Given this list of marker genes GNGT2, GNGT1, GNG5, GNB1, ADCY5, CACNA2D2, GNG4, GNB5, GNB4, GNG8, GNAI2, GNG10 (NCBI Gene Id 2790), CACNA1D (NCBI Gene Id 776), ADRA2C, GNG3, GNG2, GNAI1, ADCY6, CACNB2, ADRA2A, CACNB3, GNB2, GNG7, GNG12, GNG13, CACNA1C, GNB3, GNG11 (NCBI Gene Id 2791), here is a description of the gene set: The catecholamines adrenaline (epinephrine) and noradrenaline (norepinephrine) inhibit insulin secretion from pancreatic beta cells. Four effects are seen in the cells:<br>1. Inhibition of exocytosis of secretory granules, the major effect.<br>2. Opening of ATP-sensitive potassium channels (KATP channels) and repolarization of the cell.<br>3. Closing of L-type voltage-dependent calcium channels and inhibition of calcium influx.<br>4. Inhibition of adenylyl cyclase activity.<br>The first event in adrenaline/noradrenaline signaling in beta cells is the binding of adrenaline or noradrenaline to alpha-2 adrenergic receptors, which are G-protein coupled receptors. Binding activates the alpha subunits in heterotrimeric Gi and Go complexes to exchange GDP for GTP, forming the active G alpha:GTP complex. Experiments using specific antibodies against the alpha subunits in mice show that Gi alpha-1, Gi alpha-2, and Go alpha-2 are responsible for adrenergic effects. The exact beta and gamma subunits of the heterotrimeric G-proteins are unknown.<br>After activation by GTP, the heterotrimeric complex dissociates into the G alpha:GTP complex and the beta:gamma complex. The G alpha:GTP complex causes the inhibition of exocytosis by an unknown mechanism that involves protein acylation. This is responsible for most of the observed inhibition of insulin secretion. Additionally, the G alpha:GTP complex activates (opens) KATP channels, allowing the cell to repolarize. The beta:gamma complex inhibits (closes) voltage-dependent calcium channels, reducing the intracellular calcium concentration, and inhibits adenylyl cyclase, reducing the intracellular cAMP concentration. Reactome Pathway: Adrenaline,noradrenaline inhibits insulin secretion species: Homo sapiens part of: Regulation of insulin secretion